Given this list of marker genes SYT9, AGRN, ZNF260, IP6K1, USF2, LHCGR, GABBR1, NECAP1, ELMOD3, KCNH2, PLEKHB2, FBXW4 (F-box and WD repeat domain containing 4), USP3, HOXA3, USP2, GREM2, SYNRG, ZDHHC5, RECK, HLA-DOA, PHRF1, CTNNAL1, FRAT1, LGALS4, MROH1, CFH, MX1, SPPL2B, CWC22, DENND2B, BCL2, COL6A2, CCDC152, SLC39A4, PKP3, QSOX1, ADGRL1, CANT1, PLEKHA5, SNX13, N4BP1, F9, RAD9A, SPSB1, PCDHA10, ADGRG3, DNAJB4, MYL6, KIAA0319L, ST3GAL1, RAB33B, WNT7B, TFPI2, TEC, JARID2, FRMD8, CYP3A43, MAPK8IP3, HR, EYA2, TRAF2, BSDC1 (NCBI Gene Id 55108), ACOT8, ABCG1, SEMA4F, MIP, ITPK1, NCOA3, APOBEC1, RAPGEF4, MTFR1L, GGPS1, PEA15, IL3RA, GUCA1A, KLC4 (NCBI Gene Id 89953), CEL, CXCR4, DIAPH1, NQO1, RAP2B, SQOR, SLC22A1, CA2, LALBA, SIT1, RBM4B, CNTRL, HRH2, IL16, UBXN6, WNT11, PCSK7, RPL12, CLPS, DVL1, GCG, BLOC1S1, ZNF292, MFGE8, SLC25A25, TRIM21, PRCC, ATP9A, BRWD3, SH3BP1, HIP1R, MSL2, BRAP, TLR7, MAP2K6, PDE4B, REXO1, SOX13, FOXK1, MATK, IKZF2, SUGP2, HGF, ARHGEF25, RFX2, MAP4K3, PI4K2A, COLQ, INPP5K, TCN2, TRAFD1, KRT1, PKD1, TCF20, EEF1A2, TLE4, CYTH3, CD79B, GLRX, S1PR1, RPL22, INSM1, F2RL1, MAP7, SH3GL1, BTC (NCBI Gene Id 685), ARFGAP3, FGD3, ABCD1, ARID3B, PSAP, KLF2, KIF3C, B4GALT1, KLF4, SPATA6 (NCBI Gene Id 54558), PMPCA, SOX11, SUB1, ZYG11B, HCFC1R1, GBF1, TIMP2, SEC11C, RAB17, USP21, RASGRP2, COQ10A, EIF2AK2, MAP1LC3A, AKAP7, TBC1D20, UNC119, SLFN12, RETREG2, SURF4, RANBP10, HINT2, WBP1, TRAPPC14, TRIM13 (tripartite motif containing 13), POMC, PHF1, RPL37A, ADRB2, RALGPS2, NEDD4L, GRINA, CCKBR (cholecystokinin B receptor), BCL6, AZI2, SPINK4, RCVRN, SCEL, EXOC7, APP, PGLYRP1, ZBTB20, CD1D, AKIRIN1, DLGAP4, SIAH1, MCOLN2, NAGA, here is a description of the gene set: Differentiation of naive CD8 T cells into cytotoxic effector cells requires three distinct signals- antigen (signal 1), costimulation -B7-1 (signal 2) and cytokine, either interleukin-12 or interferon-a/b (signal 3). Interaction of naive CD8 T cells with antigen and B7-1 programs cell division and proliferation whereas the presence of cytokines- IL-12 or IFNa/b promote survival, differentiation and memory establishment. In the absence of signal 3, the cells interacting with antigen/B7-1 undergo tolerance induction. The objective of this study was to elucidate the mechanisms how the provision of signal 3 promotes differentiation and averts tolerance induction in CD8 T cells. Trichostatin A is a pharmacological agent that inhibits histone deacetylase activity, hence regulating chromatin structure and gene expression and differentiation in many cell types. Gene signature profiles of IL-12, IFNa/b and trichostatin A stimulated cells were compared to elucidate the molecular mechanisms of gene regulation. Oligonucleotide microarray analysis is carried out to determine the extent and molecular nature of the CD8 T cell differentiation program induced by IL-12 or IFNa/b in concert with antigen and B7-1 signal. from publication Agarwal P, Raghavan A, Nandiwada SL, Curtsinger JM, Bohjanen PR, Mueller DL, Mescher MF (PMID 19592655) Human Gene Set: GSE15930_NAIVE_VS_24H_IN_VITRO_STIM_IL12_CD8_TCELL_UP Genes up-regulated in comparison of CD8 T cells at 0 h versus those at 24 h after stimulation with IL12. studied in species Homo sapiens